Given this list of marker genes Nlrp3, Il20rb, Ash1l, Adcyap1, Selenos, Npy, Ins2, Gstp1, Npy5r, Adora1, Il4, Pparg, Ins1, Spn, Fcgr2b, here is a description of the gene set: Mouse Gene Set: GOBP_NEGATIVE_REGULATION_OF_ACUTE_INFLAMMATORY_RESPONSE Any process that stops, prevents, or reduces the frequency, rate, or extent of an acute inflammatory response. species: Mus musculus